The following is a description of a gene set: Human Gene Set: WP_MIRNA_REGULATION_OF_DNA_DAMAGE_RESPONSE miRNA regulation of DNA damage response studied in species Homo sapiens, and this is the list of marker genes: RRM2B, MIR203A, H2AX (H2A.X variant histone), GADD45A, MIR145 (NCBI Gene Id 406937), CDC20B, NBN, MIR29A, APAF1, MCM7, RAD50 (NCBI Gene Id 10111), MIR181A1, SFN, MIR29B1 (microRNA 29b-1), TLK1, RAD51, MIR449A, CCNB1 (cyclin B1), CCNG1, CDK6, MIR421, SESN1, MIR24-1, E2F1, MIR16-1, MIR29C, GADD45B, RPA2, FANCD2, MIR17HG, MIR223, BID, TP53, RAD52, MIR424, CHEK1, CDK1, PML, RFC1, GADD45G, ATR, MIR15A, CASP9, ATM, BAX, CHEK2, MRE11, MIR222, CDK2, MIR221, BRCA1, PRKDC, MIR195, PMAIP1, CASP8, ABL1, MIR3591, CREB1, PIDD1, MIR330, RAD1, CCND3, CDKN1A, CCND2, CCND1, FAS, MIR20A, CDK5, TP53AIP1, CASP3, ATRIP, BBC3, DDB2, MIR106B, MYC, TNFRSF10B, CYCS, SMC1A, MIR17, MDM2 (NCBI Gene Id 84825), CCNB3, RAD9A, RB1, RAD17, MIR34B, MIR373, HUS1B, CCNB2, CCNE2 (cyclin E2), MIR21, CCNE1, CDC25A, CDKN1B, CDK4, TLK2, CDC25C, MIR449B, MIR210